The following is a description of a gene set: studied in species Homo sapiens Genes in the cancer module 14. Human Gene Set: MODULE_15, and this is the list of marker genes: MAP4K1, CD37, SLC43A1, RPA3, PRG2, ME2, GNA15, RAB11A, RGS10, DDX3Y, ETS2, VRK1, DBP, STX10, ORM2, LPIN1, PPP4C, CHST1, H2BC21, SYNCRIP, EMP3, TRAF2, CTSC (NCBI Gene Id 50958), S1PR4, MAN2B1, RNPEP, IRF5, UBXN1 (NCBI Gene Id 92151), COX7B, CSF3R, MME, INPP5D (inositol polyphosphate-5-phosphatase D), NCF4 (NCBI Gene Id 4689), JUN, HLA-DQA1, WAS, MBD4, EEF1E1, GADD45A, DOCK2, ILF3, CDK6, UNG, NRIP1, CD34, RHOG, EWSR1, ITSN1, BNIP2, EDC4, CST7, PTP4A1, TRO, PCOLCE, ARHGDIG, CREG1, BOP1, VAMP7, PNP, MCM2, TFAP2B, LIPA, HOPX, SLIT2, CORO1A, CCHCR1, CD69, H2BC12, LSP1, INSIG1, SERBP1, GMFG, DOK1, ADAM19, POLA2, ZPR1, PROM1, ATF3, EVI2B, PMAIP1, RAC3, HAP1, PSD4, SFPQ, HPRT1, PLK3, GATA1, GLRX, DARS1, JUNB, SATB1, PECAM1, LCP1, MBNL1, DNM2, FADS2, CCND2, SYNGR4, CD52, ADA, TTLL12 (NCBI Gene Id 23170), RRP1B (NCBI Gene Id 23076), CXCL2, PIM1, ARL6IP5, DNMT1, PSMB8, UBE2J1, TGFB1, LRPPRC, SRSF2 (NCBI Gene Id 6427), DYRK1A, LCP2, KLHDC3, ITGA4, MYCBP, STMN1, IMPA2, GYG1, NFIL3, KDM5C, DDIT3, NOLC1, CXCR4, LGALS9, ITGA2B, APOC1, HHEX, CSNK2A1, PTPRCAP, ZIC2, ANXA1, PMF1 (NCBI Gene Id 94958), PLCG2, M6PR, CD44, CXCL8, ALDH1A1, TFRC, EIF5, FLNA, ARHGDIB, HCLS1, JARID2, BCKDHA, KRT18, MCM6, CLEC2B, MAPRE1, EIF2S3, MRPL3, DDIT4, RGS2, PTPN12, CBX3, APRT, METAP1, PLAAT4, FDFT1, MAPKAPK3, PFKFB2, PTPN9, IL2RG, SOX4, GBE1, DGKA, CKS2, BRD4, LST1, CLN3, COPS5, TBXAS1, RO60, PTPN7, MDK, HLA-DQB1, HLA-DMA, SPINK2, GALNT1, PLIN2, NMI (NCBI Gene Id 9111), DDX21, PSMB9, LYN, EIF4EBP1, RGS1, ACKR2, MTA1, GMPS, SLC7A11, FADS1 (fatty acid desaturase 1), LSM3, KIF21B, SLC25A46, TMX1, PTTG1, H2AC6, MYB, TARBP1, PITPNB, LMO2, GPA33, VBP1, SLC6A2, PCDH9, SRGN, PIM2 (NCBI Gene Id 11040), IQGAP2, ITPA, CDV3, TRANK1, PPP1R15A, HMOX2, RNASE2, NUDT1, PARP2, SCP2 (NCBI Gene Id 6342), ITGB7, CCT6A, HTRA2, PIGC, OAS2, PRIM1, SHMT2, ANPEP, PRPF19, CD47, CLIP2, ARPC4, AK2, ATP2A3, YWHAE, FABP7, MCM3, PPP2R5D, WTAP, TSPAN3, PCLAF, AKR1C3, HNRNPA0, ELMO1, CFAP410, PYGL, MYC, SERPINB1, GATA2, CRYBA4, PRKACB, PNRC1, RPA1, BIRC2, POLD2, SELL, HSD17B10, CCND3, SNRPB2, ANGPT1, RAC2, PPP5C, ZYX, LAIR1, TCF12, MLLT11, COPS2, HMGN4, PCNA, CDK5R1, TARBP2, PAICS, P2RX1, IGHM, ICAM3, MSH2, MAGI1, ARHGEF6, LMO4, NSMAF, HTR4, PRKDC, SMARCD2, PSMA4, DKK4, CCNG1 (cyclin G1), MLC1, AIF1, EFNA2, SORD, CRIP1, PSMC2, MPO, PTPRC, FZR1, RSRP1, PKN1, S100A4, ACR, NHERF1, HTR7 (NCBI Gene Id 3363), TNFAIP8, UBE2L6, MAFF, AIMP2, KCND3, SERPINE1, ZMIZ1, MPP1, EDA, FLT3, DDX3X, KRT31, SLC2A1, TNR, MAP2K3, LAMP2, LSM4, APEX1, ARHGAP4, LAPTM5, CAD, CAPG, RAP1A, SERTAD2 (NCBI Gene Id 9792), TFDP2, TP53, TYMS, SSR1, TNFRSF10B, FKBP5, MEST (NCBI Gene Id 95680), CLDN9, GPSM3, FOS, CD53, FOSB, CEP250, PLEK, H4C3, IFI16 (NCBI Gene Id 3428), PTP4A3, LRBA, MYO18A, SEPTIN6, PTK2B, VAMP5, AHSG, BYSL, WIZ, ZWINT, SEC22B, SF3A1, BMI1, CDK2, LMNB2, ADSL, IL1B, ITM2A, RAB8A